The following is a description of a gene set: species: Homo sapiens Regulation of p38-alpha and p38-beta from publication Schaefer CF, Anthony K, Krupa S, Buchoff J, Day M, Hannay T, Buetow KH (PMID 18832364) Human Gene Set: PID_P38_ALPHA_BETA_PATHWAY, and this is the list of marker genes: CCM2, MAPK14, FYN, CDC42 (cell division cycle 42), MAPK11, SRC, DUSP16, RIPK1 (NCBI Gene Id 8737), TAB1, MAP2K6, PAK2, PAK3, TRAF6, MAP3K12, PAK1, DUSP8, MAP2K3, YES1, DUSP1, MAP2K4, RALB, BLK, MAP3K3, HCK, RALA, DUSP10, RAC1, LYN, LCK, FGR